The following is a description of a gene set: Murine Cytomegalovirus (MCMV) infection leads to early activation of various immune cells, including B and T lymphocytes, before the actual initiation of antigen-specific adaptive immunity. This activation is partly driven by innate cytokines, including type I interferon (IFN), which are induced early after infection. The objective of this study was to address the role of type I IFN in shaping early/innate B and T cell responses to a primary acute viral infection. In order to decipher the specific impact of IFN-I on cell subsets, we performed a genome-wide expression analysis on WT splenic B and CD8 T lymphocytes isolated from C57BL/6 mixed bone marrow chimera mice. This study complements series GSE39555, which focused on early responses of NK cells and of the two subsets of conventional dendritic cells. species: Homo sapiens Genes down-regulated in CD8A dendritic cells: control versus primary acute viral infection. Human Gene Set: GSE45365_HEALTHY_VS_MCMV_INFECTION_CD8A_DC_DN, and this is the list of marker genes: IL2RA, CCNA1, CNIH4, NOD2, S100A9, PRKCG, SMURF2, CYRIB, IL18RAP, WNT5A, SSTR2, FCGR2B, HSPE1, NUDC, BRAP, TNFSF10, SP100, CD48, LUC7L, HIVEP2, CHST8, CDS2, WDR26, CFLAR, CD79A, SSTR3, FOXO3, PKP2, HNRNPC, FASLG, NXT2, NOTCH1, HSPA13, NPTN, TNPO1, SERPINB9, MED14, CELA2B (NCBI Gene Id 63037), DPEP3, ARMC6, TALDO1, SATB1, ADORA1, LRP12, IRS1, GNAI3, NUP58, PSMA7, SLC25A28, FPR2, TIGAR, TLR4, SERTAD3, DENND2D, PDXK, DYNLT1, CD53, ACOT9, CDR1, SCN1B, ATP13A3, ICAM2, SMCHD1, NLRP3, ARL8B, YIPF6, RRAGC, ASB6, PLSCR1, MAFB, BCL2L11, ZBTB43, FZR1, HYAL2, FOSL2, SETD1B, TICAM1, CD59, ZFP36, CDC37, SPHK1, HSP90AB1, MED8, CHIC2, DPP4, IFIT5, HLA-DRA, GYPE, NPAS1, CAV2, EREG, CORO1C, ZC3H12A, CMC2, HSPA6 (NCBI Gene Id 3310), EMC3 (ER membrane protein complex subunit 3), ADRA1B, RNF19A (NCBI Gene Id 81036), ZCCHC2, TCEAL9, CLEC2D, TESK1, FUT5, SNIP1, YME1L1, H3-3B, HLA-DMA, SOD1, GCH1, OTUD4, GSTO1, ASGR1, TJP3, IFIH1, SPSB1, CGGBP1, IRF7, LILRB1, MFHAS1, IER3, PPP3CA, DDX39A (DExD-box helicase 39A), RAB21, SLC22A6, PLA2G7, LEF1, RBM7, CD69, TFRC, NECTIN2, SAR1A, ZNF562, MAPK1IP1L, PRPF3, MARK3, CPD, DHX15, KEAP1, MSL3, CTNNAL1, CEMIP2, BST2, BID, HNRNPM, ZFYVE16, PAF1, KCNK10, NBR2, ADPRH, POGZ, RHEB, VAV1, SCNN1A, DAXX, GABARAPL1, TWF1, C1QB, ELL2, PSMA2, MT1E, AKR1B1, LTC4S, CXCL3, MMP19, MRGBP, PPP1R15A, BARD1, VRTN, TNFRSF4, GLRX (glutaredoxin), SPTBN2, ITGA9, SRC, TNFRSF1B, MAP2K3, TMEM59L, WARS1, C21orf91, TENT5A, MFN1, EMD, GATA2, SLC7A11, SARDH, PSMA3, MFSD12, TDRD7, LIMK2, RNF13, PLAGL2, NCOA1, RNF24, MAP3K8, GRB2 (growth factor receptor bound protein 2), ZC3HAV1, DOCK4, H2BC8, SOD2, LY86, TMEM140